The following is a description of a gene set: Human Gene Set: MIR4749_3P from publication Chen Y, Wang X (PMID 31504780) species: Homo sapiens Genes predicted to be targets of miRBase v22 microRNA hsa-miR-4749-3p in miRDB v6.0 with MirTarget v4 prediction scores > 80 (high confidence targets)., and this is the list of marker genes: CASTOR2, CHD8, TRPC1, GANAB, RNF167, TRPV3, CDK15, CPSF4, UNK, EMP2, NDUFB5, ATP1B2, EREG, SLC24A2, PID1, GPR26, USP5, TAFA4, OAZ2, GEN1, ESR2, GAL3ST4, DACT1 (dishevelled binding antagonist of beta catenin 1), NHP2, PDCD7, ZNF385B, C1QTNF1, FAM217B, PREP, CIC, DAZAP2, CAMK2B, TBC1D16, SYNC, MMP24, HIPK1, ATXN7L3, SLC36A2, ACTN4, PLXNA1, VPS53, FURIN (furin, paired basic amino acid cleaving enzyme), PHC2 (polyhomeotic homolog 2), CCDC140, RPRD1A, CAMK1D, BRD1, ZIC3, CADM3, DNAJC8, ZBTB10, KIRREL1, PAX8